The following is a description of a gene set: Mouse Gene Set: GOBP_POSITIVE_REGULATION_OF_HYDROGEN_PEROXIDE_BIOSYNTHETIC_PROCESS Any process that increases the rate, frequency or extent of hydrogen peroxide biosynthesis. The chemical reactions and pathways resulting in the formation of hydrogen peroxide (H2O2), a potentially harmful byproduct of aerobic cellular respiration which can cause damage to DNA. species: Mus musculus, and this is the list of marker genes: Nox4, Zfp13, Duoxa2, Duoxa1, Sod2, Mfn2